Given this list of marker genes SOS1, MAPK1, MYC, KRAS, FGFR3, GRB2, MAP2K1, ARAF, RPS6KA5, HRAS, MAPK3, BRAF, RAF1, MAP2K2, SOS2, NRAS, here is a description of the gene set: Mutation-activated FGFR3 to RAS-ERK signaling pathway. Pathway ID: N00011. Pathway type: Variant. Pathway class: nt06265 Bladder cancer. Pathway Definition from KEGG: FGFR3* -> GRB2 -> SOS -> RAS -> RAF -> MEK -> ERK -> MSK1 -> MYC species: Homo sapiens Human Gene Set: KEGG_MEDICUS_VARIANT_MUTATION_ACTIVATED_FGFR3_TO_RAS_ERK_SIGNALING_PATHWAY